Given this list of marker genes Clxn, Dnah5, Ccdc40, Dnaaf6, Dnaaf5, Dnaaf6rt, Dnai4, Dnal1, Ccdc63, Ccdc65, Dnah7c, Lrrc61, Dnaaf4, Ccdc103 (NCBI Gene Id 73293), Zmynd10, Ttc12, Dnaaf1, Dnaaf2, Dnaaf11, Dnai1, Dnah1, Dnah17, Dnai3, Daw1, Drc1, Dnah8, Tekt2, Cfap57, Dnah7a, Cfap73, Odad2, Dnai2, Odad1, Cfap100, Dnah7b, Dnah2, Spag1, Dnaaf3, Dnaaf10, Odad3, Odad4, Ccdc39, here is a description of the gene set: The aggregation, arrangement and bonding together of a set of components to form an axonemal dynein complex, a dynein complex found in eukaryotic cilia and flagella, in which the motor domain heads interact with adjacent microtubules to generate a sliding force which is converted to a bending motion. Mouse Gene Set: GOBP_AXONEMAL_DYNEIN_COMPLEX_ASSEMBLY studied in species Mus musculus